Given this list of marker genes RBCK1, WDFY3, CKAP4, ZBTB39, ZNF358, PLEKHA1, RUBCNL, U2AF1, ABCC3, PHF20, BTNL2, NOSIP, RNFT1, SOX2, TARBP1, ABCG4, ANKRD55, KIR2DS5, PLEC, HLF, RAB5C, DEXI, ILRUN, SMAGP, ASL, COQ8A, RBBP6, DPP4, SMTN, PSD3, RPL27A, MINDY1, ELMO2, HCRTR2, CTRB2, CCDC25, PKN1, DNAH17, CASP8, SLC8A2, PRR36, GRHL2, ADGRE3, CASP10, LY6D, TMEM11, PACSIN2, FOXN2, GPA33, RPS16, IGHV5-78, NR5A2, RASGRP2 (RAS guanyl releasing protein 2), SEL1L3, IL11RA, STIM1, PLOD2 (NCBI Gene Id 5352), DPF2, FAM182B, SIRT6, OTOR (NCBI Gene Id 56914), PTGER2, MIR124-1HG, PECR, DPH5, ART3, APBA2, GP5, NUDT2, SIDT2, PEX26, ITPKC, HTR7, PHF24, ZNF835, MGAT4A, MRPL46, SP110, NR2E1, LILRA4, TSC22D3, SPAG11B, RAPSN, TSPAN14, PEF1, NCK2, SDC2, SNX15, ECPAS, IRF5 (interferon regulatory factor 5), MORC2, RUNX1T1, NUP43, REXO2, COPS7A, CAT, IFT46, SLC17A7, RIMBP2, EFEMP2, SFXN3, CCDC69, SPINK4, ERAL1, NME3, HLA-DQB1, HPSE2, FGL1, ELOA-AS1, LDLRAP1, AAK1, FGF9, KLHL1, SNX2, GJD2, MT1X, DNAJC22, MID1, MYL12B, AUP1, COL18A1, RPL41, DDX28, PRKCA, TUBA4A, SORL1, INPP5B, NDRG3, PCOLCE, SPTB, LAMP5, CEMP1 (NCBI Gene Id 752014), BST2, PLAC8, PLBD1, FGFR2, SLC16A8, H1-2, LYPD1, TH, B3GNTL1, FAU, NOP10, CLUAP1, THNSL1, PDIA2, CHAT, RPL3, LRIG1, BPIFA1, SELPLG, POLR2F, NMT1, DNAJB4, PXN, EYA3, RPS2, EIF3D, EIF3K, EPHB1, SDK2, KRT33B, MSX1, ZNF692, MARK1, MKNK2, OR7E87P, PIGP (NCBI Gene Id 53821), ACP6, RPS6, PF4V1, ITPA, CLDN9, THBS1, DENND4B, RACK1, INA, PPP1R13B, SPSB3, CBY1, LAMB2, RAB11FIP5, NEURL1, POLR2J, PASK, ATAT1, JCHAIN, PIP5K1B, GDPD3, SFI1, HERC2, SCNN1B, RABIF, NPIPB15, NSFL1C, CIB1, here is a description of the gene set: studied in species Homo sapiens Genes down-regulated in comparison of CD4 thymocytes versus naive CD4 T cells from cord blood. Subpopulations of human fetal thymocyte and circulating naïve T cells were obtained through FACS sorting, including CD3-CD4+CD8- intrathymic T progenitor cells (ITTP), CD3intCD4+CD8+ \double positive\ thymocytes (DP), CD3highCD4+CD8- \single positive\ thymocytes (SP4), CD3+CD4+CD8-CD45RA+CD62L+ naive T cells from cord blood (CB4+), and CD3+CD4+CD8-CD45RA+CD62L+ naive T cells from adult blood (AB4+). from publication Lee MS, Hanspers K, Barker CS, Korn AP, McCune JM (PMID 15210650) Human Gene Set: GSE1460_CD4_THYMOCYTE_VS_NAIVE_CD4_TCELL_CORD_BLOOD_DN